The following is a description of a gene set: Human Gene Set: MODULE_22 studied in species Homo sapiens Genes in the cancer module 22., and this is the list of marker genes: CCS, NDUFS2, ATP6AP1, NDUFS8, ATP6V0E1, ATP2C1, NDUFA9, NDUFA1, ATP5F1D, ATP5MC3, ATP6V1G1, ATP5PD, NDUFB8, ATP6V0A1, ATP6V0B, ATP5MC1, NDUFB3, ATP5PO, NDUFB1, ATP5F1E, SLC39A6, ATP5ME, NDUFV2 (NCBI Gene Id 4729), ATP5MF, NDUFS4, NDUFA7, NDUFB5 (NCBI Gene Id 96666), NDUFB10, NDUFA3, NDUFC1, NDUFS3, NDUFS6, ATP5PF, ATP6V0D1 (NCBI Gene Id 9114), NDUFA5, NDUFA2, NDUFV1, ATP6V0C, NDUFS5, ATP5F1A, NDUFA4, ATP5MC2, NDUFB7, NDUFA6, NDUFAB1